The following is a description of a gene set: Genes with low-CpG-density promoters (LCP) bearing the tri-methylation mark at H3K4 (H3K4me3) in MCV6 cells (embryonic fibroblasts trapped in a differentiated state). from publication Mikkelsen TS, Hanna J, Zhang X, Ku M, Wernig M, Schorderet P, Bernstein BE, Jaenisch R, Lander ES, Meissner A (PMID 18509334) Mouse Gene Set: MIKKELSEN_MCV6_LCP_WITH_H3K4ME3 Somatic cells can be reprogrammed to a pluripotent state through the ectopic expression of defined transcription factors. Understanding the mechanism and kinetics of this transformation may shed light on the nature of developmental potency and suggest strategies with improved efficiency or safety. Here we report an integrative genomic analysis of reprogramming of mouse fibroblasts and B lymphocytes. Lineage-committed cells show a complex response to the ectopic expression involving induction of genes downstream of individual reprogramming factors. Fully reprogrammed cells show gene expression and epigenetic states that are highly similar to embryonic stem cells. In contrast, stable partially reprogrammed cell lines show reactivation of a distinctive subset of stem-cell-related genes, incomplete repression of lineage-specifying transcription factors, and DNA hypermethylation at pluripotency-related loci. These observations suggest that some cells may become trapped in partially reprogrammed states owing to incomplete repression of transcription factors, and that DNA de-methylation is an inefficient step in the transition to pluripotency. We demonstrate that RNA inhibition of transcription factors can facilitate reprogramming, and that treatment with DNA methyltransferase inhibitors can improve the overall efficiency of the reprogramming process. species: Mus musculus, and this is the list of marker genes: Mr1, Ggnbp1, Mrgprf, Nr1h5, Klk11, Xaf1, Rnase1, Gbgt1, Ikbke, Lgals3bp, Spef2, Anxa1, Zfp583, Gpr21, Kcnip3, Lgals9, Aldh1a1, Il17re (NCBI Gene Id 57890), Gpank1, Crb1, Aoc1, Ptprv, Acy3, Pspn, Tnks1bp1, Sh3kbp1, S100a3, Akr1c14, Myot, Isg20, Robo4, Tapbpl, Pipox, D630023F18Rik, Kcnn4 (potassium intermediate/small conductance calcium-activated channel, subfamily N, member 4), Cd244a, Rufy4 (RUN and FYVE domain containing 4), Glmp, 1700010I14Rik, Kif1c, Krtdap, Cyp4f13, Slc13a2, Snx10, Galnt15, Trim40, Tmem248, Prx, Fxyd3, Tnfsf13, Pstpip1, Wars1, Muc1, Vwa5a, Tnfsf10, Rbm10, Ifi35, Fgfbp1, Nyap1, Trim21, Kcnk7, Tmem176a, G430095P16Rik, Ccdc9, Gcnt3, Lbp, Zbtb20, Zbp1, Arhgef11, Notch4, Fabp7, Dapk3, Il17rc, Cyp2j6 (NCBI Gene Id 13110), Adgrg1, Gstm2, Them5, Rsad2, Lst1, Dab2ip, Btc, Oas2, Chst4, Csf3, Il7r, Rnf151, Nherf2 (NCBI Gene Id 76520), Styxl2, Cfap126, Gpa33, Aldh3b1, Mab21l3 (mab-21-like 3), 6820408C15Rik, Platr26, Zscan2, Tmem176b, Adamts13, Aspdh, Tns4, Dqx1, Iqsec2, Gsta3, Ces2g, Pcolce, Tns2, Ccdc120, Trex1, Mrps21 (NCBI Gene Id 66292), Serpinb8, Slc29a1, Akna, Gpsm3, Angptl2, Arhgdib, Cfh, Zmym2, Xdh, Nppb, Emp3, Gpr173, Pdzk1ip1, Gpr165 (NCBI Gene Id 76206), Zfand6, Ifitm1, Tgm3, Sytl1 (NCBI Gene Id 83670), Aldh3a1, Gbp2, Sipa1l3 (signal-induced proliferation-associated 1 like 3), Zfp57, Msln, Vtcn1, Rab17, Scara5, Myo1g, Arap1, Unc13d, Hexim2, Plekha6, Chit1, Ankrd49, Cox7a1 (NCBI Gene Id 12865), Tbc1d10c, Syne3, Gpr35, Plekhs1, Laptm5, Col6a1 (collagen, type VI, alpha 1), Ripor2, Usp54, Urb2, Fgd4, Pinlyp, Elovl1, Prelp, Slfn2, Serpinb9, Rnf123, Prickle3, Mark2, Glrx, Cab39, Rorc, Slc25a45, C1rl, Evi5, Prrg2, Otop2